The following is a description of a gene set: studied in species Mus musculus Mouse Gene Set: REACTOME_UNFOLDED_PROTEIN_RESPONSE_UPR Unfolded Protein Response (UPR), and this is the list of marker genes: Eif2s3x, Mbtps2, Eif2s2, Creb3l3, Crebrf, Mbtps1, Ern1, Atf6b, Eif2s1, Atf6, Creb3